Given this list of marker genes UPP2, GCSH, GPI, MDH2, PPP3CA, CCDC138, P3H3, NADK, SRA1, ZC3H12A, ABLIM3, EFNB2, SYT7, DNAJC9-AS1, MFSD1, ENSG00000293341, SMIM19, SGMS1, GIT1, KLF4, TMEM123-DT, SGMS1-AS1, URGCP, USP46-DT, VDR, KIF1B, KLC2-AS2, FRS3, DHCR24-DT, CTSD, TEDC1, FSCN1, CPAMD8, GPBP1 (GC-rich promoter binding protein 1), VWA1, SEMA3F, RANBP1, NANOS1, MISP3, BAIAP2, PIGW, VPS28, AKR7A2, ZNF10, MICAL1, RHEB, TBC1D1, PPP3CB-AS1, SLC35E1, PRPF40A (NCBI Gene Id 55660), TNRC6C (trinucleotide repeat containing adaptor 6C), SUPT4H1, PPP1R14B, ACVR1, MPHOSPH6, IRX5, PITX3, AK4, IMMT, GAB2, PARP4, YBEY, ABCF1, GAA, SEPHS1, TATDN2, PPP5D1P, ACVR2A, SFXN5 (NCBI Gene Id 94097), VPS13D, LINC01976, RBM43, SGK3, ENSG00000253986 (NCBI Gene Id 105379327), TOB1-AS1, FYN, PAX6, STIM2-AS1 (STIM2 antisense RNA 1), C2CD2, OSGIN2, SLC22A31, BAIAP2-DT, USP45, VAMP8, ZMYM2, CDHR2, SYDE2, TMEM123, ASIC1, CDHR3, SETD7, TTC3, PRELID2, ZBTB46, EPC2, MIR4710, DNMBP, MTCL2, PFKL, TBL1XR1, TBC1D8, THEM6, BBLN, RNF141, LINC01971, GINS2, VIM, INTS15, IRAG1-AS1, ARVCF, RAB1B, BCL7A, IFFO2, MAN1A2, SLC20A2, MYO19, CD24, MSANTD2 (Myb/SANT DNA binding domain containing 2), DDX20, LIMK1, ITPR3, DOK1, LEISA1, ARHGEF19, RASGRP2, ULK4 (unc-51 like kinase 4), ZNF277, ZNF709, POMGNT2 (NCBI Gene Id 84892), RHPN2, RCN1, BHLHE40, TPPP, ARHGAP21, RASGEF1C, BCR, ANO8 (anoctamin 8), TDRKH, KCTD15, NOL4L, BAHD1, MLF1-DT, ARRB1, GPD1L, LRP10, NDST1-AS1, PRR12, RO60, CLIP2, ENSG00000263011, MTMR10, PLCB2, TRIB1, ANKRD18DP, ZMIZ1, SLC25A33, TULP4, NRBP2, NUDT16L1, HOOK3, CLCN2, CRLF1, KCNJ11, ANKRD19P, ZNF891, PACSIN2, PPP1R13B, NMT2, SLC10A4, STK17B, TAL1, NOTUM, SSBP4, ATXN7L3, LITATS1, ATP1B2, NELFA, SIAH1, MAP3K8, MXD4, REPIN1 (NCBI Gene Id 96712), GNB4, ZNF775, TRIM33, OTULIN-DT, TIGAR, PSMG2, SEC22C (SEC22 homolog C, vesicle trafficking protein), RAPGEFL1, PINK1, DNAJC16, EMD, GALNT1, INKA2, CDKN1C, BSDC1, SP3, CRAMP1, LSM3, DEF8, ANXA6, VHL, PPP1R26, MLF1, RAD51C, ZEB1, FUT11, MCM3AP, PHLDA2, NR3C2, NARS2, SLC30A3, PHF19, PLEC, TRPC1, CKB (creatine kinase B), TCF19, RNF170, MIDEAS, EFCAB15P, SNX30, PPARA, DCBLD1, GDF5, ACAP3 (ArfGAP with coiled-coil, ankyrin repeat and PH domains 3), GFOD1, TONSL, PNCK, PHF10, SLC66A1, MAFA, BNIP3, CCHCR1, ZNF248, CALM1, C11orf68, CTBP1-DT, FN3K, SNX30-DT, PPP1R13B-DT, ATP6V0E2, PPP1R3E, ILK, ISYNA1 (NCBI Gene Id 51477), LONRF1, NAV2, CYP46A1, POFUT2, CFAP97 (cilia and flagella associated protein 97), AMZ2, NDST1, DOK4, ZNF670-ZNF695, SCARNA2, DCTN1, PNPLA8, HBEGF, CLTCL1, N4BP2, VPS26A, PARP10, NFATC1, CCNYL1, BMI1, DRAP1 (DR1 associated protein 1), DHRS11, CRBN, E2F7, KIFC2, B3GNT5, PPP2R5B, SDF2L1, VPS37D, B4GALT7 (NCBI Gene Id 202179), IQGAP3, FBRSL1, ESPN, SOCS2, ARL6IP6, PIGC, ANXA4, TDH-AS1, KHDRBS3, CDK6, MEGF9, L3MBTL3, CALU, CALM3, PIGP, ERICH2-DT, AQP3, XPC, LINC02482, PTDSS1, YOD1, AKAP1-DT, MSRA-DT, WDR41, FAM216A, RRN3, IRF2BP2, PLEKHH2, NOSIP, PFKP, SSH2, SRRM3, SNX25, SC5D, WDR27, PAOX, ERBB3, TEAD1, MEX3A, WWC2, MIR4664, PHACTR2, KRTAP5-AS1, TGIF2, RAB30-DT, SLC6A8, GRINA, ATP1A1, ZMIZ1-AS1, SPRED2, ZSWIM6, SOCS3-DT, UCHL5, KMT5B, PURA, PRKAG2, CNOT11, BEND6, PRELID3A, BCRP8, MYCL, TMEM268, PYGL, TENT5C-DT, AKAP1, ID3, USF2, BTNL9, PHAF1, MAP3K3, MRPL11, TOR1B, TRNP1 (NCBI Gene Id 388610), DNM1, TEX14, AKT1, PTCH1, ACBD7, CA8, CD99P1, IL6ST, C6orf136, PLAGL1, LLGL2, USP46, AKAP8, TNK2, ZNF670, SOCS3, MED15, SUB1, CDH24, CDC42BPA, MEAF6, NKTR, UGCG, PPP3CB, PI4KA, RNF19A, CPEB2-DT, FBXO31, ZBTB18, DPY19L1, MAFF, DMTN, IQANK1, PCGF1, NFIB, RCOR3, PSMA7, TRABD-AS1, TCAIM, MELTF-AS1, RBPJ, ACAT1, ANKRD13B, MIR3188, NUDT3, RPP25L, CTNNA1-AS1, SUN1, MPHOSPH6-DT, BCAP29, CASP9, MIEF2, ARID1B (AT-rich interaction domain 1B), SLC43A1, RAP1GAP, MAPK15, CDC14B, TOR3A, WDR91, GNB2, FNBP1, VPS26B, ZNF248-AS1, AHDC1, APOLD1 (NCBI Gene Id 81575), RPS10P29, TAF4, SUPT7L, PELI3, MICALL1, SS18L1, AXIN2, TGIF2-RAB5IF, GARNL3, TM7SF3, RRP8, TMPPE, RPL7, STK35, TRMT2A, FGFRL1, GALNT12, PDSS2, ZNF280D, GLI4, DNMT3B, ENSG00000207751, CEP250, ANXA2, LIN9, TTL, GGH, TLNRD1, SNAP29, KDF1, PMS2P3, LPGAT1-AS1, ZNF318, GK5 (glycerol kinase 5), RMND1, EPHX1, PIGU, VASP, GARRE1, PLEKHO1, SLC25A28, ARMT1, DUSP8, MARCHF8, DLGAP4-AS1, AMZ2P1, CRNDE, GNG7, PLCG2, GADD45B, RUNX1, MTURN, PARP6, DCUN1D1, GTPBP3, SNAI3-AS1, CASZ1, STIM2, PFKFB2, LIMD2, CRELD1, ZEB1-AS1, ENSG00000254531, ACBD4, EGLN3, RHOG, ANKRD18CP, CTNNA1, SLC39A8, IL17RA, SNHG7, KCNQ4, GPN3, LPGAT1, PLEKHA8, MSANTD2-AS1, CPEB2, CAMSAP2, CTBP1, GLIPR2, GABBR1 (NCBI Gene Id 2550), DGKA, ATXN7L1, GLB1, IL6ST-DT, MAP3K14-AS1, FSTL3, B4GALNT1, PIK3R1, SLC2A4RG, USP25, BMP8A, RDH10, SPECC1L-ADORA2A, C6orf120, ARHGEF10, MLXIPL, TCF7, POLR2H, MED13L, GGCX, NALF1, MTERF3, ADAM15, DST, SNX24, SLC25A28-DT (SLC25A28 divergent transcript), ADAMTSL4, CILK1, RAB40B, RNF19B, KAT2B, SLC4A1AP, ENSG00000283078, JADE1, ZNF324B, SNAI3, HES2, MALINC1, ATF3, SPECC1L, YPEL1, CDK5R1, SDCBP, COPRS (NCBI Gene Id 95076), TMEM109-DT, NAB1, MAPKBP1, MIDEAS-AS1, FAM83H, MVD, NCAPD3, ZFTRAF1, LDHA, MIDN, RXRA, AHNAK, JUND, CDYL, PUSL1, LNCOC1 (lncRNA associated with ovarian cancer 1), STAP2, SLC2A8, TENT4A, PPFIA3, ZNF512B, here is a description of the gene set: from publication Yevshin I, Sharipov R, Kolmykov S, Kondrakhin Y, Kolpakov F (PMID 30445619) studied in species Homo sapiens Human Gene Set: PCGF1_TARGET_GENES Genes containing one or more binding sites for (PCGF1) in their promoter regions (TSS -1000,+100 bp) as identified by GTRD version 20.06 ChIP-seq harmonization.